The following is a description of a gene set: species: Mus musculus Reactome Pathway: mRNA Polyadenylation This event has been computationally inferred from an event that has been demonstrated in another species.<p>The inference is based on the homology mapping from PANTHER. Briefly, reactions for which all involved PhysicalEntities (in input, output and catalyst) have a mapped orthologue/paralogue (for complexes at least 75% of components must have a mapping) are inferred to the other species. part of: mRNA 3'-end processing electronically inferred by orthology from the curated human pathway, and this is the list of marker genes: Srrm2, U2af1l4, Ubb, Tut1, Srsf8, Srsf5, Phf5a, Cdc40, Sf3b5, Polr2i, Snrpa1 (small nuclear ribonucleoprotein polypeptide A'), Polr2c, Sugp1, Snrpf, Snrpg, Polr2a, Polr2b, Snrpc, Hnrnph1, Smndc1, Polr2e, Rbm5, Cpsf1, Snrpn, Ppp1ca, Hnrnph2, U2surp, Pcbp1, Rps27a, Rbmx, Papola, Polr2l, Clp1, Hnrnpk, Fip1l1, Prr3, Srsf10, Cpsf3, Srsf3, Hnrnpf, U2af2, Hnrnpr, Gtf2f2, Papolg, Polr2k, Sf3a3, Wdr33, Ptbp1, Pcbp2, Srrt, Rbm17, Dhx15, Gtf2f1, Polr2f, Snrpa